The following is a description of a gene set: species: Homo sapiens Impaired ability to repeat non-word sounds. The test for nonword repetition involves the repetition of nonsensical words of increasing length and complexity and is regarded as a measure of phonological (speech sound) processing and short-term memory Human Gene Set: HP_DEFICIT_IN_PHONOLOGIC_SHORT_TERM_MEMORY Deficit in phonologic short-term memory, and this is the list of marker genes: MAPT, RRM2B, RNASEH1, PRNP, GSN (NCBI Gene Id 2934)